Given this list of marker genes DBNDD2, MACF1, ZBTB44, DHDDS, SIRT1 (sirtuin 1), PPP4R3A, SMAP2, SEMA4C, SMG1, PDE7B, L3MBTL3, DVL2, MIER3, RPS6KA1, DCUN1D4, JAZF1, CLMP, ABCB9, SCN1B, SOX12, MNT, GPR3, COTL1, MSI2, MYEF2, MOV10, KCNMA1 (NCBI Gene Id 3778), MAFG, JOSD1, MGAT5B, PFN2, LSM14A, GLI2, ZFAT, NR4A3, C14orf180, CASTOR3P, GALNTL6, PTPN2, TULP4, SH2B3, RMND5A, ZNF609, RARA, TP53INP2, IQSEC2, DSCAM, ANKRD54, ANXA6, KMT5B, SLC17A7, CDK2AP1, MIEF2, BTG1 (NCBI Gene Id 694), ZNF444, GATAD2A (NCBI Gene Id 54815), SNCB, BCL11A, RHOC, MEAF6, BAIAP2, DNAJB6, ZBTB4, ELOF1, UIMC1, MOCS1, USP10 (NCBI Gene Id 9100), SEPTIN11, PABPC1L2A (poly(A) binding protein cytoplasmic 1 like 2A), CTDSPL2, DHX57, DENND1A, ZNF518A, CALN1, OBSCN-AS1, ZFP36L2, C6orf47, UBE2Q1, KLF11, KBTBD4, CLK2, SUGP1 (NCBI Gene Id 57794), TMTC4, ZCCHC14, EPHA8, FEM1C, KLHL35, RAVER1, SORBS2, MAP2K7, MAP3K11, ZER1, USP47, PSMF1, IGF2BP2 (NCBI Gene Id 10644), NSMF, SPTB, RIMS3, THRB (NCBI Gene Id 7068), MCU, RALGPS1, NEXMIF, UBAP2, VPS26A, DLEC1, TTC7B, SENP1, CPEB4, MTCL2, TSR1, DTX1, SOX4, HDAC4, PELI3, OSBPL3, BMP1, CSE1L, NPTX1, INHBB, ST3GAL3, JMJD8, PTP4A1, CNOT8, NEBL, PAPPA (pappalysin 1), DESI2, JMJD1C, LHFPL3, LZTS3, CACNA1E, ADGRL3, PTPN11, MUC4, TRPS1, THAP11, NSD3, H3-3B, MIER2, ADAMTSL3, KCNH7, SEH1L, LIMK1, ZFHX3, SOBP (sine oculis binding protein homolog), AHCYL2, PPARGC1A, ATP11C, NCOA1, PDE3A, FRMD4A, ZMYND11, SLC6A8, PHOX2B, ZNF385A (NCBI Gene Id 25946), EZH2, ZC3H7B, BNIP3L, EGFLAM, CLUH, KIAA0930, FERMT2, CPT1B, UNC5D, NFIX, RREB1, RSF1, KAT6A, AFF3, EPB41L4B, PEDS1-UBE2V1, UBP1, EID1, VSTM2L, EFNB3, NBEA (neurobeachin), AMMECR1, ZNF775, TPM4, EPHA4, SLC35F1, LYPLA1, ARHGEF3, ZMIZ1, SMURF1, ANK1, SLC10A7, GPATCH2L, UBE2V1, ADCY1, SRRM4, RCAN2, TRAM1, ARL4C, CIT, CLVS1, MLLT6, UNC5A, SLC20A1 (NCBI Gene Id 6574), CHKB, SHFL, AGO1, ARF1, MSI1, CLNS1A, SIN3A, PCSK2, PTK2, ERC1, CLK3, BAZ1B, ARRDC3, CORIN, NKAPD1, PDIK1L, ELFN2, TIPARP, ZNF607, CBFA2T2, CCNE1, RELN, INO80D, ZEB2, DCP1A, MXD4, PRP4K, YDJC, ROCK2, here is a description of the gene set: Genes having at least one occurence of the motif CACCAGC in their 3' untranslated region. The motif represents putative target (that is, seed match) of human mature miRNA hsa-miR-138 (v7.1 miRBase). Human Gene Set: CACCAGC_MIR138 species: Homo sapiens